The following is a description of a gene set: Human Gene Set: GOBP_NLS_BEARING_PROTEIN_IMPORT_INTO_NUCLEUS studied in species Homo sapiens The directed movement of a protein bearing a nuclear localization signal (NLS) from the cytoplasm into the nucleus, across the nuclear envelope., and this is the list of marker genes: KPNA6, RANBP2, KPNA4, RGPD6, RGPD5, RGPD1, RGPD8, KPNB1, RGPD4, IPO5, KPNA5, NUP35, RGPD3, KPNA3, NUP54, CBLB, KPNA7, KPNA1, RGPD2, KPNA2